Given this list of marker genes C1R, CCN2, NR4A2, GPHA2, SYVN1, PPT2, HSPA5, TH, CREM, HDAC7, RASGRP1, CLU, PSAT1, ITGB1, PTGS1, GAD2, IFNA7, here is a description of the gene set: species: Homo sapiens Our previous study revealed that Vav3 oncogene is overexpressed in human prostate cancer, activates androgen receptor (AR), and stimulates growth in prostate cancer cells. The purpose of this study is to further determine the potential role of Vav3 in prostate cancer development in genetically engineered mouse model. We generated Vav3 transgenic mice by targeted overexpression of a constitutive active Vav3 in the prostatic epithelium. We found that overexpression of Vav3 led to development of mouse prostatic intraepithelial neoplasia and prostate cancer at the age of as early as 3 months. The AR signaling axis and phosphatidylinositol 3-kinase-Akt signaling were elevated in the prostate glands of Vav3 transgenic mice. In addition to prostate cancer, Vav3 transgenic mice developed significant nonbacterial chronic prostatitis in the prostate gland with notable infiltration of lymphomononuclear cells (monocytes, lymphocytes, and plasma cells), which was associated with elevated incidence of prostate cancer. DNA microarray and signaling pathway analysis revealed that the top diseases and disorders were inflammatory diseases and cancer of the prostate gland in Vav3 transgenic mice. In vitro analysis showed that overexpression of Vav3 in prostate cancer cells enhanced nuclear factor-kappaB (NF-kappaB) activity, implicating an underlying mechanism of innate inflammatory response induced by elevated Vav3 activity. These data showed that Vav3 overexpression in the prostate epithelium enhanced both the AR signaling axis and NF-kappaB-mediated pathway, which potentially contributed to the development of nonbacterial prostatitis and prostate cancer. Human Gene Set: LIU_VAV3_PROSTATE_CARCINOGENESIS_DN from publication Liu Y, Mo JQ, Hu Q, Boivin G, Levin L, Lu S, Yang D, Dong Z, Lu S (PMID 18676865) Selected genes down-regulated in prostate tumors developed by transgenic mice overexpressing VAV3 in prostate epithelium.